Given this list of marker genes Gm2387 (predicted gene 2387), Aard, Rad21, Slc30a8, Utp23, Trps1, Gm19303, Gm23545, Gm48923, Rpl15-ps6, Ext1, Gm34678, Gm27926, Gm34562, Gm48913, Gm23200, Gm41322, Eif3h, Gm2361, Mir28c, 1700015H07Rik, Gm19236, Gm7543, Gm34794, Mir1907, Med30, here is a description of the gene set: species: Mus musculus Mouse Gene Set: chr15C